The following is a description of a gene set: TFAP2 (AP-2) family regulates transcription of growth factors and their receptors species: Homo sapiens Human Gene Set: REACTOME_TFAP2_AP_2_FAMILY_REGULATES_TRANSCRIPTION_OF_GROWTH_FACTORS_AND_THEIR_RECEPTORS, and this is the list of marker genes: TFAP2C, ATAD2, ERBB2, CGB8, VEGFA, KIT, TFAP2B, TFAP2A, TGFA, CGB3, YY1, CGA, ESR1, EGFR, CGB5